Given this list of marker genes Capn12, Capn13, Capn2 (NCBI Gene Id 98318), Capn9, Capn3, Capns2, Capn10, Capn5, Capn11, Adgb, Capns1, Capn1, Capn6, Capn15, Capn7, Capn8, here is a description of the gene set: species: Mus musculus Catalysis of the hydrolysis of nonterminal peptide bonds in a polypeptide chain by a mechanism using a cysteine residue at the enzyme active center, and requiring the presence of calcium. Mouse Gene Set: GOMF_CALCIUM_DEPENDENT_CYSTEINE_TYPE_ENDOPEPTIDASE_ACTIVITY